The following is a description of a gene set: studied in species Homo sapiens The process in which the anatomical structures of the forebrain are generated and organized. The forebrain is the anterior of the three primary divisions of the developing chordate brain or the corresponding part of the adult brain (in vertebrates, includes especially the cerebral hemispheres, the thalamus, and the hypothalamus and especially in higher vertebrates is the main control center for sensory and associative information processing, visceral functions, and voluntary motor functions). Human Gene Set: GOBP_FOREBRAIN_MORPHOGENESIS, and this is the list of marker genes: FGF8, SMO, NF1, WNT5A, PROP1, PTEN, SLIT1, UCHL5, TUBA1A, GDF7, HESX1, GSX2, OTX1